The following is a description of a gene set: Mouse Gene Set: REACTOME_TRAFFICKING_OF_AMPA_RECEPTORS studied in species Mus musculus Trafficking of AMPA receptors, and this is the list of marker genes: Pick1, Cacng2, Grip1, Grip2, Prkcg, Gria1, Dlg1, Ap2m1 (NCBI Gene Id 11773), Dlg4, Gria2, Cacng4, Ap2b1, Gria4, Gria3, Camk2b, Ap2s1, Camk2d, Cacng3, Tspan7, Camk2g, Cacng8, Mdm2, Prkcb, Camk2a, Ap2a2, Akap5, Myo6, Ap2a1, Nsf